The following is a description of a gene set: Human Gene Set: REACTOME_INTERLEUKIN_12_SIGNALING Interleukin-12 signaling species: Homo sapiens, and this is the list of marker genes: PAK2, GSTA2, IL10, BOLA2B, RALA, IL12RB1, SOD1, MTAP, JAK2, SNRPA1, CDC42, PPIA, ANXA2, HNRNPDL, CA1, JAK1 (NCBI Gene Id 3716), SOD2, AIP, RPLP0, CFL1, SERPINB2, IL12RB2, CAPZA1, MIF, IFNG, TYK2, RAP1B, TCP1, IL12A, HSPA9, TALDO1, GSTO1, STAT4, PITPNA, VAMP7, CNN2, MSN, HNRNPF, LMNB1, HNRNPA2B1, BOLA2, ARF1, LCP1, PSME2, PDCD4, IL12B, P4HB